The following is a description of a gene set: Human Gene Set: WP_SARSCOV2_REPLICATION_ORGANELLE_FORMATION SARS-CoV-2 replication organelle formation studied in species Homo sapiens, and this is the list of marker genes: PIK3C3, ATG14, PIK3R4, BECN1, ZFYVE1, AMBRA1